Given this list of marker genes Wnt3, Plxna2, Shh (NCBI Gene Id 20423), Fgf10, Zfp219, Ext1, Sema3c, Col2a1, Sox9, Fgfr2, here is a description of the gene set: Mouse Gene Set: GOBP_LIMB_BUD_FORMATION The process pertaining to the initial formation of a limb bud from unspecified parts. This process begins with the formation of a local condensation of mesenchyme cells within the prospective limb field, and ends when a limb bud is recognizable. studied in species Mus musculus